Given this list of marker genes Ccr5, Slc40a1, Ikbkb, Il4, Kcnj6, F2r, Trpc6, Atp6v1b2 (NCBI Gene Id 97492), Kcnv1, Kcna5, Coro1a, Slc39a3, Atp6v0e2 (NCBI Gene Id 76252), Kcnq1, Akap9, Rnasek, Ccl21b, Slc6a14, Asic2, Scn3b, Slc39a14, Ccl19-ps5, Ndufs3, Pkd2l1, Slc45a3, Slc6a6, Ibtk, Cxcl10, Atp2a3, Tmem94 (NCBI Gene Id 71947), Ndufa10, Atp6v1g2, Ccdc51, Gp9, Slc38a2, Atp6v0a2, Lyn, Afg3l2, Cd19, Scn3a, Ryr1, Cacna2d1, Tcn2, Gp1bb, Bin1 (NCBI Gene Id 30948), Flna, Sri, Kcnt2, Alg10b, Tmem175, Ptk2b, mt-Co2, Hcn4, Ccl3, Atp5f1b, Slc9a1, Plcg1, Kcng3, Slc12a5, Jsrp1, Slc4a5, Fyn (NCBI Gene Id 14360), Otop3, Kcnmb2, Trpv3, Cxcr3, Tgfb2 (NCBI Gene Id 98738), Kcnk1, Chp1, Diaph1, Epo, Rgs9, Slc12a7, Slc24a1, Snap25, Letm1, Asic3, Cyba, Vmp1, Slc30a5, Maip1, Cacng7, Slc5a6, Jph3, mt-Co1 (NCBI Gene Id 99197), Slc18a3, Ptprc, Slc25a5, Micu2, Kcnj3, Calm3, Calm2, Fxyd7, Tcirg1, Atp6v0d1, Tmem63b, Kcnb2, Scn2a, Ptpn22, Ano6, Gpr39, Hcn2, Grxcr1, Trpm2, Slc5a4b, Hspa2 (heat shock protein 2), Wnt3a, Abcb8, Ccl21e, Kcnk7, Casq2, Slc4a10, Snca, Fhl1, Slc41a2, G6pdx, Slc24a2, Gjc2, Abcb7, Kcna7, Cd63, Slc30a6, Cacnb2, Ccl19-ps4 (NCBI Gene Id 100040035), Tmem165, Cacng2, Atp2b1, Atp5f1a, Slc25a12, Atp6v1e2, Atp6v0e, Uqcrh, Steap3, Pml, Rgs4, Cnnm4, Plcl2, Asic4, Wwp2, Kcne2, Ndufa4, Slc38a4, Kcnn2, Rgs7, Slc11a1, Ccl19, Kcnj15, Cbarp, Slc6a3 (NCBI Gene Id 13162), Grin2b, Cngb3, mt-Cytb, Tescl, Gp5, Slc38a5, Ccl21f, Cnksr3, mt-Nd4, Casq1, Kcnc2, Stk39, Kcnmb1, Slc6a16, Atp6v1c2, Lime1, Tmem37, Slc45a1, Slc30a3 (solute carrier family 30 (zinc transporter), member 3), Atp13a2, Kcnc4, Slmap, Slc34a3, Slc4a4 (solute carrier family 4 (anion exchanger), member 4), Slc30a4, Slc39a2, Phb2 (NCBI Gene Id 12034), Rangrf, Fasl, Spg7, Ubr3, Bhlha15, Nipal4, Nalf2 (NALCN channel auxiliary factor 2), F2rl3 (NCBI Gene Id 14065), Kcnc1, Cyc1, Hap1, Kcnk10, Slc9a2, Kcne5, Itpr3, Scnn1a, Slc18b1, Trpv4, Cacng4, Ncs1, Prkd1, Slc1a3, Atp5pb, Ppif, Tmem150c, Panx1, Scn2b, Kcnk3, Otop2, Atp2a1, Clcn7, Slc13a5 (NCBI Gene Id 405903), Atp13a4, Mcub, Cacna1a, Clcn3, Slc25a25, Trpc7, Fcrl5, Bpifa5, Slc25a28 (NCBI Gene Id 75661), Kcnh4, Prnp, Tmem74, Stac2, Slc36a1, Atg5, Cnga2, Plcb2, Slc4a8, Scnn1b, Plcb4, Kcnt1, Tmco3, Kcna6, Capn3, Cxcl9, Cacna1g, Slc29a4, Slc24a4, Atp5mf, Atp4a, Slc6a17, Xcl1, Atox1, Slc25a3, Tmem38a, Tfrc, Slc12a2, Kcnj10, Sec61a1, Cherp, Slc8b1, Pkd1l3, Slc9c1, Kcnq4, P2rx3, Tgfb1, Dbi, Slc41a3, Kcnc3, Slc17a8, Atp6v1e1, Scn1a, Slc4a9, Nipal3, Scara5, Kcnrg, Fbxo11, Kcnk4, Jph2, Atp2b4, Plcg2, Ap3d1, Kcnab1, Atp4b, Trpc4, Zdhhc13, Bcl2, Atp1a1, Camk2d, Itgb3, Ccl19-ps1, Kcna3, Hpca, Cacna1h, Slc38a1, Cacna2d2, Gp1ba, Letm2, Gpd1l, Slc18a2, Cox4i2, Ghitm, Drd1, Trpc2, Slc31a1, Cacna1s, Nherf1, Grin2c, Tpcn1, Lrrc52, Pkd1, Grin3a, Slc39a5, Pirt, Kcnn4, Slc30a8, Cacnb4, Bak1, Abcc2, Htr2c, Atp1b2, P2ry12, Slc8a3, Cblif, Kcnv2, Atpsckmt, Slc31a2, Nppa, Asic5, Slc6a9, Arf1, mt-Atp6, Slc4a7, Atp2b3, Atp2b2, Atp6v0a1, Slc6a21, Mcoln3, Atp5mc1, Sting1, Lcn2, Atp13a3, Surf1, Ifng, Nos1, Atp5f1e, Slc9a7, Kcnj9, Slc28a3 (NCBI Gene Id 64079), Iscu, Nedd4l, Plcb3, Tmc2, Slc25a18, Gria2, Ndufv1, Atp12a, Bmp4, Zfas1, Slc17a7, Ywhae, Kcnh5, Cacna2d3, Fxyd4, Kcnk15, Ddit3, Catsper2 (NCBI Gene Id 212670), Kcnk9, Kcnj5, Kcnab3, Slc13a3, Prkce, Ndufs4, Nipa1, Slc13a1, Kcnq3, Nipa2, Gper1, Mrln, Hamp, Kcna10, Slc36a2, Slc41a1, Myo5a, Hrh1, Hcn3 (hyperpolarization-activated, cyclic nucleotide-gated K+ 3), Cacng3, Atp5mc3, Slc39a9, Romo1, Best2, Slc25a4, Scn11a, Slc32a1, Slc25a23, P2rx6, Crbn, Tlr9, Smdt1, Kcnn3, Dmac2l, Adrb2, Grp, Slc9a4, Sumo1, Htr2a, Fmr1, Slc6a20b, Sestd1, Tesc, Fgf2, Calhm1, Kcnk5, Atp5po, Plch1, Bdkrb1 (NCBI Gene Id 12061), Scn5a, Xcr1, Lhcgr, Oxsr1, Atp6v0a4, Slc6a15, Aqp1, Sco1, Ccl21a, Kcnf1, Ppp3ca, Fkbp1a, Ndufv2, Slc45a2, P2rx7, Atp6v1g1, Ndufs7, Kcnb1, Trpm4, Pik3cg, Kcnh1, Cacna1c, Kcnh6, Tmem109, G6pd2, Cemip, Itgb1, Hpn, Kcnab2, Atp2c1, Cnga4, Slc25a14, Lrrc55, Atp1a2, Trpm6, Slc39a12, Fgf14, Slc47a1, Slc34a2, Snta1, Actn2, Ndufa2, Gpm6a, Slc1a1, Atp6v1c1, Tmem38b, Kcnk2, Ndufs2, Kcnk12, Commd1, Trpa1, Kcns2 (K+ voltage-gated channel, subfamily S, 2), Catsper3, Kcnj2, mt-Nd2, Plcl1, Rem1, Il13, Kcnj12, Cav1, Gsto1, Gstm7, Adra1a, Atp1b3, Atp1b1, Slc39a11, Kcnd1, Slc5a1, Ngf, Kcna1, Slc6a5, Nr3c2, Itpr2, Trpv5, Slc39a13, Slc39a4, Tmem63a, Vdac1 (voltage-dependent anion channel 1), Drd4, Ppp3r1, Orai2, Slc8a1, Gas6, Nalcn, Cacna1e, Agtr1a, Slc9a3, Uqcrfs1, Slc5a3, Orai1, Atp6v1d, Stimate, Cftr, Stac, Cacna2d4, Fxyd1, Clec4b1, Ppp3cb, Atp5me, Rnf207, Akap7, Asph, Grin2a, Atp6v0c, Glp1r, Steap1, Abl1, F2, Cacng1, Large1, Ank3, Mmp9, Ank2, Dlg1, Kcne4 (potassium voltage-gated channel, Isk-related subfamily, gene 4), Scn4a, Atp5pd, Slc23a1, Trpv6, Kcng1, Ppp3cc, Bax, Tmco1, Scn1b, Stim1, Kcnj1, Ehd3, Npsr1, Cacna1i, Kcns1, Slc36a3, mt-Nd5, Ywhah, Mettl21c, Cxcl11, Slc20a2, Slc6a1, Kcnip2, Ano9, Kcnq2, Fxyd5, Panx3, Piezo2, Slc47a2, Slc30a2, Abcc9, Slc6a13, Atp6v1f, Ptpn6, Atp6v1h, Lrrc26, Ano10, Kcne1, Trpm3, Trpm5, Cacna1b, Slc30a1, Slc6a20a, Psen2, mt-Nd3, Ednrb, Atp2c2, Pln, Aplnr, Hcn1, Cacnb3, Fxyd2, Ucp2 (NCBI Gene Id 22228), Gal, Hif1a, Fxn, Edn3, Ntsr1, Tpcn2, Kcnk6, Kcnj14, Calm1, C2cd6, Trpv1, Sphk2, Trdn, Cacnb1, Slc6a2, Micu3, Kcnn1, Fxyd3, Drd2, Ero1a, Kcne3, Scn4b, Atp13a5, Pik3c2a, P2rx2, Steap4, Ahnak, Kcns3, Kcnh2, Atp7a, Atp6v1a, Slc46a1, Micu1, Cnga1, Kcnd2, Slc9a9, Atp1a4, Tmem63c (transmembrane protein 63c), Slc6a4, Catsper1, Grm7, Ednra, Tmem168, Oprk1, Slc6a18, Trpm8, Otop1, Dhrs7c, Nol3, Slc11a2, Mmgt1, Slc6a7 (NCBI Gene Id 240332), Stac3, Ppp3r2, Wnk3, Kcna4, Slc46a3 (solute carrier family 46, member 3), Cracr2a, Coa8, Homer1, Wnk1, Slc15a2, Slc12a3, Atp6v0b, Atp1a3, Pdpk1, 1810037I17Rik, Nedd4 (NCBI Gene Id 639396), mt-Nd6, Slc9a6, Slc12a4, Nipal1, Ndufs1, Kcnj8, Bpifa1, Pde4d, Slc45a4, Atp6v1b1, Tmbim6, Slc24a3 (NCBI Gene Id 94249), Slc30a10 (NCBI Gene Id 226781), Abcc5, Scn10a, Cacng6, Adrb1, Htr2b, Kcnu1, Ryr3, Ctss, Slc6a19, Ryr2, Ahr, Ubash3b, Mcoln2 (NCBI Gene Id 99673), Cnga3, Amigo1, Ccl19-ps6, Fgf12, Hvcn1, Kcnj11, Cacna1d, Gm13629, Hspa9, Akap5, Gpr35, Rapgef3, Scn7a, Trpv2, Slc12a1, Kcnma1, Nalf1, Grin2d, Kcnj13, Taco1, Dpp10, Slc39a6, Plcb1, Pawr, Gimap3, Atp6v0d2, Slc24a5, Trpc5, Ucp1, Ndufb7, P2ry6, Mcur1, Grm6, Kcnh3, Neto1, Slc6a8, Atp6v1g3, Slc13a2, Piezo1, P2rx5, Itpr1, Ccl19-ps3, Wnk4, Kcnk18, Plch2, Ptger3, Plp1, Ccl21d, Ucp3, Atp7b, Slc48a1, Cacng8, Slc34a1, Pkd2 (NCBI Gene Id 77380), Ffar1, Ndufs8 (NADH:ubiquinone oxidoreductase core subunit S8), Opa1, Grin3b, mt-Atp8, Cd4, Tusc3, Slc9b1, Kcnj4, Cox7a1 (cytochrome c oxidase subunit 7A1), Nipal2, Slc22a1, Slc4a11, Scn9a, Edn1, Lck (lymphocyte protein tyrosine kinase), Gimap5, Slc39a8, Smim6, Atp5f1d, Kcng2, Gnb2, Slc39a1, Thy1, Slc30a7, Slc15a1, Mrs2, Kcnd3, Ms4a1, Slc9a8, mt-Nd1, Galr2, Chd7, Lrrc38, Slc15a4, Slc17a6, Ms4a2, Ubqln1, Psen1, Cav3, Wnk2, Catsper4, Strit1, Pcsk9, Adcyap1r1, Atp5pf, Cnnm2, Trpm7, Mcoln1, Atp2a2, Grin1, Abcb6, Tmem163, Dysf, Mcu (mitochondrial calcium uniporter), Mmgt2, Fxyd6, Atp5mg, Heph, Slc35g1, Slc12a6, Trpm1, Orai3, Itgav, Ptpn3 (NCBI Gene Id 545622), Htt, Hrc, Akt1, Cx3cl1, Cacna1f, Pkd1l1, Slc12a8, Sln, Cox17, Dpp6, Kcna2, Hamp2, Atp6ap2, Slc25a37, Slc39a7, Oga, Kel, Trpc3, Tmc1, Slc39a10, Kcnmb4, Slc25a22, Slc5a2, Slc9a5, Kcnh7, Kcnip1, P2rx1, Atp5f1c, Atp5mc2, Stim2, Cngb1, Dmd, Prss8, Ccn2, Gnb5, Kcnk16, Agrn, Kcnip3, Kcng4, Kcnip4, mt-Nd4l, Nipsnap2, Nnt, Slc20a1, Plce1, P2rx4, Slc5a4a, Asic1, Fgf13, Ctns, Slc9b2, Kcnq5, Steap2, mt-Co3, Scnn1g, Osr1, Slc6a11, Kcnj16, Kcnh8, Vamp2, Kcnk13, Akap6, Slc8a2, Slc18a1, Scn8a, Selenon, Atp6ap1, Slc30a9, Trpc1, Tspan13, Slc25a27, Slc25a13, Fkbp1b, Calhm3 (calcium homeostasis modulator 3), Slc6a12, Slc16a1, here is a description of the gene set: Mouse Gene Set: GOBP_MONOATOMIC_CATION_TRANSMEMBRANE_TRANSPORT species: Mus musculus The process in which a monoatomic cation is transported across a membrane. Monatomic cations (also called simple cations) are positively charged ions consisting of exactly one atom.